Given this list of marker genes PLD4, CDK6, TOP2A (NCBI Gene Id 7153), ZBTB1, SOS2, RBM47, ANLN, INHBA, AP3B1, METTL3, LIG4, TCF15, MYB, ITCH, PUS7 (NCBI Gene Id 54517), WDR38, TMEM91, HMGB1, REST, MIXL1, TP53, ARL11, SETD1A, HES5, ANKLE1, SERPINB12, VEGFA, SIPA1L3, LIPA, HYAL2, PTPRZ1, FSTL3, BMP4, HOXB4, SP7, SSBP3, EXT1, KITLG, SFRP1, TMEM190, DPF2, MED1, HES1, MEOX1, HEATR9, EIF2AK2, ABL1, CEBPD, SOX4, PTPRC, KDR, PRRC2C, AGPAT5, BATF, SLC8A3, RRS1, TIFAB, ZNHIT1, SIN3A (NCBI Gene Id 25942), BRAF, RLIG1, TMSB4X, NOTCH1, SP3, FLCN, ACE, N4BP2L2, HERC6, GATA3, CIAO3, PYGO1, DNAI4, PDGFRA, LMBR1L, TREX1, SBDS, KRT75, PDCD2, ZNF784, ZFAT, MLF1, SRF, KIT, FST, SOS1, ADAR, ESCO2, NFE2L2, SPI1, BVES, YTHDF2, CHD2 (NCBI Gene Id 283680), XRCC5, METTL14, TGFB1, KAT5, PCID2, EML1, SHH, ERCC2, DHTKD1, ARMC6, ATF2, EEF2, PRKDC (NCBI Gene Id 5591), HSPA9 (heat shock protein family A (Hsp70) member 9), PTPN6 (NCBI Gene Id 5777), FLT3, SH2B3, CITED2, GATA2, BCL2, DHX36, SMPD3, OSM, SLC7A6OS, UFL1, JAM3, ACP6, MMP21, ZBTB24, DACT2, HOXB3, NUDT21, TENT2, PLEK, FBXO21, TNFRSF13B, FNIP1, WDR7, FOXC1, LYN, MLLT3, TAL1, RARA, PSEN1, here is a description of the gene set: studied in species Homo sapiens The process in which precursor cell type acquires the specialized features of a hematopoietic progenitor cell, a class of cell types including myeloid progenitor cells and lymphoid progenitor cells. Human Gene Set: GOBP_HEMATOPOIETIC_PROGENITOR_CELL_DIFFERENTIATION